Given this list of marker genes ASNS, FOS, POLR3A, GNPNAT1, FLNA, PDGFRB, PPARG, MEN1, UPF3B, HERC1 (NCBI Gene Id 8925), CAVIN1, SIM1, FIBP, AIP, PIGL, AGPAT2, RPS6KA3, NSD1, SUZ12, RNU4ATAC, PACS1, CAV1, NF1, EED, INSR, KMT5B (NCBI Gene Id 54794), UBE3B, BSCL2, SETD2, here is a description of the gene set: Human Gene Set: HP_LONG_FOOT studied in species Homo sapiens Increased back to front length of the foot. Long foot